The following is a description of a gene set: Mouse Gene Set: GOBP_CHONDROITIN_SULFATE_PROTEOGLYCAN_METABOLIC_PROCESS The chemical reactions and pathways involving chondroitin sulfate proteoglycans, which consist of a core protein linked to a chondroitin sulfate glycosaminoglycan. The chondroitin sulfate chain is composed of the repeating disaccharide unit beta-(1,4)-D-glucuronic acid-beta-(1,3)-N-acetyl-D-galactosamine, the latter of which can be O-sulfated. species: Mus musculus, and this is the list of marker genes: Chpf, Pxylp1, Chst12, Ugdh, Chsy1 (NCBI Gene Id 269941), B3gat2, Csgalnact2, Chpf2, Chst7, Chst13, Galnt3, Dsel, B3galt6, Slc35b2, Galns, Arsb, Hyal1, Chst11, Cytl1, Gusb, Xylt2, Hexb, Csgalnact1 (chondroitin sulfate N-acetylgalactosaminyltransferase 1), Hyal4, Bpnt2, Xylt1, B3gat1, B3gat3, B4galnt3, Chst3, B4galnt4, Slc35d1, Dse, Igf1 (insulin-like growth factor 1), Chsy3, Ext1